The following is a description of a gene set: Human Gene Set: MIR8082 from publication Chen Y, Wang X (PMID 31504780) Genes predicted to be targets of miRBase v22 microRNA hsa-miR-8082 in miRDB v6.0 with MirTarget v4 prediction scores > 80 (high confidence targets). studied in species Homo sapiens, and this is the list of marker genes: ARHGAP12, NCAPH, GNG2, MTMR14, VPS53, NETO1, LRRTM2, SRPX, KLHL42, NAB1, CLCA2, ZNF213, ALDH16A1, ARHGAP28 (NCBI Gene Id 79822), ST6GAL1, NUMBL, GNG13, ALG12, NR6A1, CMTM7, TSPAN14, IGF2, DAAM2, RNF10, NOP9, SLC35E1, FCMR, C2CD5, FUNDC2, CSTPP1 (centriolar satellite-associated tubulin polyglutamylase complex regulator 1), PPP3R1, RDH10, OLA1, SCN2B, AKAP13, ZMYND11, ATP12A, TNRC18, TAOK3, BCL2L11, FAM222B, PLCXD2, FAM120C, GPR84, FXR2, ETV7, MTCL1, CER1, PGR, ADAM12, HGSNAT, PURG (purine rich element binding protein G), GSG1L, EIF4E, INTS6, BET1L, FAM169BP, MYO18A, MARK1, CACNG3 (NCBI Gene Id 10368), SMURF1, EFHC1, HOMER1, ZNF813, TMEM168, MS4A1 (NCBI Gene Id 931), CNOT9, WWC1, ASAP2, KCNS1, CCDC121, ERICH3, CCND2, DTNA, SPAG17, MILR1 (NCBI Gene Id 284021), LIMCH1, XIRP1, SRGAP2, TENT2, NUBP1, KDM2A, ZNF142, GFRA1, MR1, TRPA1, SCN3B, TOM1L2 (target of myb1 like 2 membrane trafficking protein), ALDH9A1, VWC2, AP4E1, JARID2, FAM217A, ESRRG, UGDH, MIEF1, IGLON5, FAM161A, SPN, SOX6, PPAT, CCDC40, FOXQ1, REL, HMGCLL1, GNPDA1, JMJD6, SH3BGRL3, FNDC10, SLC35F2, RGL1, GLT8D1